Given this list of marker genes ANXA8L1, ANXA5, SCGB1A1, HLA-DOA, ANXA2, HLA-DMB, HLA-DRA, ANXA4, HLA-DRB4, LGALS4, LGALS3, HLA-DOB, LGALS1, LGALS7, ANXA3, ANXA1, MRC1, here is a description of the gene set: species: Homo sapiens Human Gene Set: MODULE_543 Annexin, MHCII, and lectins.